Given this list of marker genes PPP1R1C (NCBI Gene Id 89799), MED28, DSG2, PRKCE, MAGEL2, ZNF705EP, SPIN3, TUT4, NUAK1, SLC39A9 (NCBI Gene Id 55334), CTNNA3, ANKRD44, NT5DC3, TNFAIP8, CADM2, CAMKK2, NPTX1, ATP8A1, NELL1, STX5, EBF1, FOXN3, SLC25A46, SLC39A1, INSIG1, HDAC9, ZNF280B, SEC24A, CNOT6, PRTG, PPP1R2, MOB1B, AJUBA, ARHGEF7, GJA3, SINHCAF, ADAM22, PRKACB, SPAG9, CCN4, FBXW11, ABTB3, CCDC59, PHKA2, CD96, CGGBP1, EDNRB, ZNRF1, SH3KBP1, MAP1B, SEPHS1, ARHGAP6, PAIP1, PRRG3, GXYLT2, TNS1, RIMBP2, PTPN4, NFIC (NCBI Gene Id 4782), SATB2, CNMD, RPAP2, DOCK9, UBASH3B, PURA, KCTD2, SIN3B, GABRB1, BTLA, XPR1, RTKN2 (rhotekin 2), MBLAC2, DOK4, KIAA1217, MAGI1, ARHGEF3, JRKL, EGLN1, DENND1B, SLC1A1, GRB2, FAM43A, EIF5, PCNX1, LDB3, RPRD1B, PGR, PTPRG, TMEM64, CUL5, PPP1R13B, CNTN1, SP3, CYB5B, TMEM50B, SETD9, PIK3AP1, APPL1, LHX1, TRPM6, VPS26B, A1CF, SLC2A3, VAV2, DENND5B, DEPDC4, NF1, CTTN, FRS2, MAPK9, ABCA2, SPIN1, MTCH2, PLPPR4, ST8SIA1, CERS2, SLC35G1, ARHGDIA, NUDT13, NRCAM, FOXRED2, REPS2, VLDLR, BNC2, TAGLN3, SLC30A7, OAS3, VAMP3, PCMTD1, ZFC3H1, THBS2, MAK, CDV3, CORO1C, TARBP1 (NCBI Gene Id 6894), RELL1, CD59, ZBTB20, DOCK4, AQP9, STOX2, RICTOR, USP6NL, CREB3L1, HAS2, RETREG1, MYRIP, SYPL1, MINDY3, RAPGEF4, ZC3H12C, OPN1MW, TMEM170B, TAF15, ZNF705A (zinc finger protein 705A), TRIO, NCKAP1, DENR, YWHAG, FAM218A, SLC23A2, APBA2, HBEGF, HIF1AN, WFDC8, PHF21A, TNS3, TBR1, MED14, SLITRK4, GSPT1, SERINC5 (serine incorporator 5), CBFA2T3, TMEM150C, AATK, TAPT1, CREB1, L1CAM, AREL1, SNAI2, FAM171A1, RNF222, POLR1F, KCNJ14, SH3BGRL, DOCK1, USP13, HEXIM1, SLC1A2, ZFAND4, MED21, SEPTIN7, ZHX1, SPRY4, RNF208, SLC2A14, TMEM245, DCUN1D3 (NCBI Gene Id 123879), SV2C, PAIP2, GPR22, MEF2C, CHMP1A, ADGRL2, RAB2A, BCL2L12, YIPF4, REEP1, EIF3J, FLOT1, MRTFB, MFAP3, SKIL, SEPTIN9, SELENOI, FOXN2, CHST10, SLC22A5 (solute carrier family 22 member 5), PCDH8, TSPAN9, RBM5, PTAR1, OLFM1, SLC4A7, BPNT2, DEPTOR, CAMSAP2, RAB27B, CEP170B, OSBPL10, RNF212, ADAM18, KPNB1, NRN1, PTGR2, FERRY3, FBXO27, TLL1, GLB1L, LMTK2, STK19, ADAMTS18, ADGRF5, PPP1R11, HYCC2, ATAT1 (alpha tubulin acetyltransferase 1), FAM91A1, SETX (senataxin), GIT2, ZNF451, ITPR1, LGI1, WNT5A, FOXO3, SLCO3A1, AHCYL1, DYRK2, IGSF3, UGT2B17, APC, CDC42BPA, SERTAD4 (SERTA domain containing 4), F13A1, FMR1, KTN1, RAB6B, SLC30A1, PYGO2, USP5, EIF5A2, SH3BP5, FLRT2, PPIL1, WASL, ARMC1, MFAP3L, ARCN1, MMD (monocyte to macrophage differentiation associated), LRIG1 (leucine rich repeats and immunoglobulin like domains 1), PALLD, C5orf22, EMB, MTSS1, MAST4, DENND6A, BCL11A, KIF19, CACNB4, KCNK9, ELL, LIMS1, BOD1L1, DYNLT3, SPAG17, BMPR1B, RNF43, FGF9, RIMS3, PHF13, PPP4R2, SLC33A1, JAZF1, RPS6KA6, CHST1, PHAF1, BRPF3, INO80D, KHDC4, FBXO42, FOXF2, PPM1F, WWC2, ADCY6, MED1, SLC16A9, GPR85, MLLT1 (NCBI Gene Id 56930), SUV39H2, PPP3CA (protein phosphatase 3 catalytic subunit alpha), BAG4, ACER3, GRM5, MEGF11, RAB10, PDS5B, FAM78A, ABHD17B, KLHL4, EPAS1, ACTR2, SMAD1, KDELR1, HMGCLL1, PRUNE2, ALG13, GNAQ, VEZT, FNDC3B, TMEM47, VAT1L, MITF (NCBI Gene Id 7487), RHOJ, UBE2Q2, B3GNT2, BACH2, BRMS1L (BRMS1 like transcriptional repressor), DAZAP2 (NCBI Gene Id 9802), KLHL34, SAMD5, CEP83, CAMTA1, CDK6, SHOC2, SEPTIN14, SAP30L, NEXMIF, ADD3, ZNF200, LPP, DKK2, PIK3R1, PHIP, ZC3H15, B3GALT1, PPM1L, SMIM13, SDC2, RGS5, SESN3, INTS6, DYNC1LI2, MSN, ZNF706, FYCO1, NUFIP2, PDZD8, ZNF704, ELAVL4, LRCH2, TENM4, CHMP2B, MORF4L2, CCNY (NCBI Gene Id 219771), SLAIN2, NID1 (nidogen 1), RHOBTB1, TBC1D12, MYO1D, PBX2, SGMS1, TOB1 (NCBI Gene Id 10140), RALGPS2, OCRL, CFL1, TACC1, MECOM, YES1 (YES proto-oncogene 1, Src family tyrosine kinase), QKI, ZCCHC3, NKX2-2, RECK, SERPINB2, NCOA4, KLF13, CASTOR2, LSM14A, STAG1, DCUN1D1, TMEM115, CHIC1, CLPTM1L, ZFP36L1, PREPL, CACNA2D1, CNNM3, TOPORS, PRRT3, MFSD6L, MSH4, ANKIB1, AAGAB, COL25A1, RWDD4, TMEM145, DMXL1, FRMD5 (FERM domain containing 5), PRKAA2, CDH20, HOXA9, GPC1, WDR76, EIF3A (eukaryotic translation initiation factor 3 subunit A), ZFAND5, EOMES, SOX6, ANXA11, RAD23B, KDM2B, PCCA, UNC13C, PASK, SLC44A2, IGDCC3, TECTB, RHD, RASA2, CITED2, CYLD, RARG, SYNCRIP, PABIR1, LRTM1, LRP10, AQP2, RAPGEF5, IGF1R, BORCS8 (BLOC-1 related complex subunit 8), AAK1, ZNF697, NCALD, SMKR1, OPN1LW, SRSF6, TP53INP1, CLOCK, SAMTOR, RNF139, ARHGEF2, BOD1L2, SPAST, ZFP36, FAM168A, ONECUT2, L3MBTL3, SH2D1A, OTUD6B, ABHD13, FLNB, TEX2, PDZRN4, RGS17, CYB561, ARF4 (ADP ribosylation factor 4), SPATA13, SHC4, PC, PLCB4, JMJD1C, NUDT15, CDC73, PLEKHG3, REV1, N4BP1 (NCBI Gene Id 9683), HOOK3, TAF4B, GNAO1, CEBPA, NADK2, LAMC1, SPIRE1, GXYLT1, CD164, PPP1R13L, TRIM37, RTN4, NDP, RASA1, AEBP2, DIAPH3 (NCBI Gene Id 81624), RAB3GAP2, EGR3 (early growth response 3), SLC35A5, ZXDA, CRISP3, TMEM198, TMEM170A (NCBI Gene Id 124491), OPN1MW2, CHAMP1, PPP3R1, WIPI2, PAN2, C21orf91, LRP3, SCML4, ZCCHC14, PRDM16, FBXW7, CLCN5, RFTN1, OOEP, CCDC117, AASDHPPT, OXR1, PAX5, EBF3, CEP250, FZD3, BNIP3, PEDS1, TSNAX, ATP10D, MBNL2, PHYHIPL, ADRA2C, PAFAH1B1, TXNL1 (NCBI Gene Id 9352), DAAM1, PEG10, ELAPOR2, GK, DQX1, TRABD2B, MIGA1, WDR47, SLC44A5, SNX30, H6PD, TOX, KLF15, ELMO1, ANKRD27, EVI5, DSCAM, FXR1, MAP4K4, CD2AP, THBS1, ELL2 (elongation factor for RNA polymerase II 2), MAPRE1, here is a description of the gene set: Genes predicted to be targets of miRBase v22 microRNA hsa-miR-182-5p in miRDB v6.0 with MirTarget v4 prediction scores > 80 (high confidence targets). Human Gene Set: MIR182_5P studied in species Homo sapiens from publication Chen Y, Wang X (PMID 31504780)